Given this list of marker genes Nckap1, Cacng1, Ttc38, Ado, Slc12a8, Trim2, Ttc7, Btbd9, Usp46, Otud4, Arrb1, Gid4, Scara5, Chmp1a, Marchf5, Rgs9, Arid3b, Klf6, Klhdc8a, Tyrp1, Gapdhs, Syngr3, Tmem150a (NCBI Gene Id 232086), Zfp704, Mlst8, Evl, Ccbe1, Lrrc59, Niban3, Ccdc85b, Ccr9, Rag1, Rtn4, Slc39a14, Tapt1, Atp6v1a, Tex35, Hmbs, Tlk1, Rab18, Pik3ip1, Hapstr1, Ttc34, Polr3e, Chrna3, Abhd4, Asxl2, Hycc1, Lmbrd1, Foxp2, Siah2 (NCBI Gene Id 99497), Car7, Serpina3i, Fam163a, Fndc5, Snx1, Styx, Itgb1bp1, Sptbn1, Decr2 (2-4-dienoyl-Coenzyme A reductase 2, peroxisomal), Frmd4b, Zcchc2, Tmem132e, Gcnt3, Sec31b, Nkd2, Tiparp, Vsnl1, Cckbr, Fastkd2, Rabgef1, Kcna6, Hmgxb3, Slc7a1, Aak1, Pctp, Rnf38, Casp8, Serpina3n, Fam135a, Rnf114, Pou2f1, Adcy1, Mkln1, Fam83f, Mcu, Sufu, Adam9, Fat4, Satb2, Vps52, Tarbp2, Pdpk1, Xrn1, Dock3, Ralgapa1, Fmn1, Ppp1r3e, Mfap1b (microfibrillar-associated protein 1B), Naa80, Eeig2, Malrd1, Mroh6, Rbm41, Fbxl16, Znrf3, Jade1, Slc39a12, Sort1, Gcsam (germinal center associated, signaling and motility), Lrsam1, Myrfl, here is a description of the gene set: studied in species Mus musculus Genes predicted to be targets of miRBase v22 microRNA mmu_miR_671_5p in miRDB v6.0 with MirTarget v4 prediction scores > 80 (high confidence targets). from publication Chen Y, Wang X (PMID 31504780) Mouse Gene Set: MIR_671_5P